Given this list of marker genes Wnt11, Bmpr1a, Serpinb7, Creb1, Myb, Il13, Serpinf2, Tyrobp, Hif1a, Itgb6, Cd46, Met, Smad4, Lum (NCBI Gene Id 17022), Cd24a, Cd2ap (NCBI Gene Id 98065), Col3a1, Foxp3, Atp6ap2 (ATPase, H+ transporting, lysosomal accessory protein 2), Gata6, Tgfb2, Smad3, Tsku, Xcl1, Furin, Ptgs2 (NCBI Gene Id 19225), Fn1, Psg22, Fbln1, Fermt1, Cd200, Itgav, Cx3cl1, Ifnb1, Atf2, Laptm4b, Thbs1, here is a description of the gene set: The appearance of any member of the transforming growth factor-beta family of cytokines due to biosynthesis or secretion following a cellular stimulus, resulting in an increase in its intracellular or extracellular levels. Transforming growth factor-beta family members include TGF-B1, TGF-B2, and TGF-B3. species: Mus musculus Mouse Gene Set: GOBP_TRANSFORMING_GROWTH_FACTOR_BETA_PRODUCTION